The following is a description of a gene set: The uptake of amino acid neurotransmitters by neurons or glial cells. This process leads to inactivation and recycling of neurotransmitters. Human Gene Set: GOBP_AMINO_ACID_NEUROTRANSMITTER_REUPTAKE studied in species Homo sapiens, and this is the list of marker genes: SLC6A13, SLC6A11, CLN8, SLC6A1 (solute carrier family 6 member 1), PER2, SLC6A12, KCNJ10, ITGB1, ATP1A2, SLC17A8